The following is a description of a gene set: Genes predicted to be targets of miRBase v22 microRNA hsa-miR-200a-5p in miRDB v6.0 with MirTarget v4 prediction scores > 80 (high confidence targets). Human Gene Set: MIR200A_5P from publication Chen Y, Wang X (PMID 31504780) species: Homo sapiens, and this is the list of marker genes: NR4A1, MORC3, HIVEP3, LRRC57, NSG2, ATP6V0A2, COPS8 (COP9 signalosome subunit 8), NCF2, TXNRD3, ZNF254, SULT1C2, PPRC1, PCDHB6 (NCBI Gene Id 56130), FGF13, FOXD1, RAB1A, GRHL1, DNAJC27, C18orf54, BTBD1, SP3, ZNF396 (zinc finger protein 396), KMT2E, KDM2B, KIAA1217, NDFIP1, POU2AF2, ARL13B, ATG10 (NCBI Gene Id 83734), LIMCH1, ZNF770, AHR, ATAD2, KLHL5, EID1, SERINC3, PAPOLG, NDFIP2, LMTK2, PLPP3, MDFIC, GOLGA7B, TXNDC17, ZC3H12C, SLC25A40 (solute carrier family 25 member 40, NCBI Gene Id 55972), COL4A1, SHPRH, KLF7, INSIG2, HAUS6, CRLF3, ZNF367, UBR3, MYBL1, PKP2, THAP5, ENKUR, MOBP, TMEM39A, BEST3, EIF1AX, RAB11B, SEMA3E, ZNF763, ALX4, MIER3, ARC, CHD7, BICRA, KCTD12, ZNF493, EPHA5, ASNSD1, AMMECR1, IFT52, SCOC, CRIM1, ETFDH, NFIA, USP53, IL1RAP, OPRM1, NSD2, ZNF440, TASOR2, TIAM2, RANBP3, HPDL, ZNF99, SLC22A15, PPM1E, EIF4ENIF1, SNX4, EPM2AIP1, ZNF675, HCFC2, GLS, ZNF138, FOXC1, ZNF91, SGK1, AGPAT5, SH3RF1, HOXA10, ZNF208, BBX